Given this list of marker genes Tafa3, Nr1h3, Grn, Bpi, Pparg, Lrfn5, Syt11, Tff2, Cst7, Fam76b, Cd200, Ldlr, Il4, Adgrf5, Nr1d1 (nuclear receptor subfamily 1, group D, member 1), Cx3cl1, here is a description of the gene set: Any process that stops, prevents, or reduces the frequency, rate or extent of macrophage activation. Mouse Gene Set: GOBP_NEGATIVE_REGULATION_OF_MACROPHAGE_ACTIVATION species: Mus musculus